Given this list of marker genes porB, CALR, APOB, SCARF1, HSP90AA1, HYOU1, HSPH1 (NCBI Gene Id 9835), here is a description of the gene set: SCARF1 (SREC-I) and SCARF2 (SREC-II) are transmembrane proteins that contain multiple extracellular EGF-like domains. SCARF2 may be involved in cell adhesion rather than ligand binding. species: Homo sapiens Reactome Pathway: Scavenging by Class F Receptors part of: Binding and Uptake of Ligands by Scavenger Receptors